Given this list of marker genes Cops5, Dnajb9, Agr2, Hspa5, Bfar (NCBI Gene Id 67118), Ficd, Pdia6, Ddrgk1, Tmem33, Ufl1, here is a description of the gene set: Any process that modulates the frequency, rate or extent of the IRE1-mediated unfolded protein response. Mouse Gene Set: GOBP_REGULATION_OF_IRE1_MEDIATED_UNFOLDED_PROTEIN_RESPONSE species: Mus musculus